The following is a description of a gene set: studied in species Mus musculus Cytokines mediate cell-cell communication in the immune system and represent important therapeutic targets. A myriad of studies have highlighted their central role in immune function, yet we lack a global view of the cellular responses of each immune cell type to each cytokine. To address this gap, the authors created the Immune Dictionary, a compendium of single-cell transcriptomic profiles of more than 17 immune cell types in response to each of 86 cytokines (>1,400 cytokine-cell type combinations) in mouse lymph nodes in vivo. A cytokine-centric view of the dictionary revealed that most cytokines induce highly cell-type-specific responses. For example, the inflammatory cytokine interleukin-1β induces distinct gene programmes in almost every cell type. A cell-type-centric view of the dictionary identified more than 66 cytokine-driven cellular polarization states across immune cell types, including previously uncharacterized states such as an interleukin-18-induced polyfunctional natural killer cell state. Mouse Gene Set: CUI_CDC2_APRIL_RESPONSE_DN from publication Cui A, Huang T, Li S, Ma A, Pérez JL, Sander C, Keskin DB, Wu CJ, Fraenkel E, Hacohen N (PMID 38057668) Genes negatively differentially expressed in cell type: cDC2 (conventional dendritic cell type 2) upon treatment with cytokine: APRIL in mouse lymph nodes in vivo., and this is the list of marker genes: Fosb, Atf3, Dusp1, Fos, Ppp1r15a